The following is a description of a gene set: Genes predicted to be targets of miRBase v22 microRNA mmu_miR_1912_3p in miRDB v6.0 with MirTarget v4 prediction scores > 80 (high confidence targets). from publication Chen Y, Wang X (PMID 31504780) species: Mus musculus Mouse Gene Set: MIR_1912_3P, and this is the list of marker genes: Rnf13, Capza1, Csrnp1, Lrrc4c, Phf13, Chd7, Trim33, Slc8a1, Klhl14, A930018P22Rik, Unk, Clvs2, Robo2, Heg1, Cyld, Mndal, Wrnip1, Taok1, Cd200, Gabra6, Senp8, Lypla1 (NCBI Gene Id 18777), Aldh1a3, Rora (RAR-related orphan receptor alpha), Il1rapl2, Eif2s3x, Kmt2a, Grsf1, Nup205, Kcnk10, Rab7, Zmym2, Zcchc14, Gramd1c, Golm2, Fzd3, Tent5d, Slc39a13, Phf12, Rnmt, Vcl, Dazap2, Cav2, Gsr (glutathione reductase), Ube2n (NCBI Gene Id 93765), Zfp850, Cul4b, Zfp735, Kctd18, Stxbp5, Tmem163, Ide, Gls, Psap, Enpp2, Rgs16, Erbb2, Stab2, Pdpk1, Zfp704, Nap1l5, Eml5, Sec23a, Slc4a7, Acsl3, Ugcg (NCBI Gene Id 97164), Emc6, Cert1, Ttll7, Dapp1, Clcn3, Zfhx4, Tmbim1, Zdhhc24, Chd3, Zswim6, Asph, Rufy3, Ebf1, Ogfrl1, Pfkfb3, Pcbp1, Arnt2, Mea1, Atp7a, Serpina5, Itsn1, Ptprj, Serpine2, Rbbp5, Thumpd1, Fndc3b, Zfx, Zfp616, Ankrd13c, Krtap1-3, Lrrc7, Col19a1, Hsf2, Hipk3, Apbb2, Serpinb9f, Mapk6, Srsf7, Hoxb8, Rab40b, Hapstr1, Scai, Bdp1, Zeb2 (zinc finger E-box binding homeobox 2), Larp1, Ehmt1, Appl1, Magoh, Ppargc1a, Tgfb2, Tbx18, Sox5, Zfp608, Klf12, Lin54, Lrfn5, Dnajb4, Spred1, Sephs1, Sdc2, Ykt6, Tm7sf3, Trpc5, Lrba, Mapre1, Sytl5, Slc9a6, Rfx4, Gata3, Slc4a10, Tafa2, Synj1, Khdrbs3, Pnn, Sh3bgrl, Tmed8, Kcna1, Sult2a4, Slc16a6, Lrrn3, Kif13a, Dlx1, Ifi211, Ikzf2, Sgms1, Ttc3, Nup153, Ehd1, Lmod2, Bend4, Pdyn, Caprin1, Bmt2, Znrf3, Trem3, Asz1, Mapk10 (NCBI Gene Id 319641), Pptc7, Patj, Sorcs1, Eeig2, Recql, Ehbp1, Tdp2, Hoxd10, Mta1, Malt1, Nrip1, Nfat5, Ube2d1, Aak1, Arpc5, Hook3, Canx, Cep126, Cnot6, Atp2a2, Dpp10, Cxcl12, Efna5, Serpinb9g, Bmp7, Abca8b, Kcnj14, Cerk, Phf20, Ccdc126, Klhl31, Ube2g1, Bdnf, Ints8, Pbrm1, Zfhx3, Unc5d, Hdgfl3, Arhgef7, Stk31, Llph, Pcbp2, Prrg3 (NCBI Gene Id 208748, proline rich Gla (G-carboxyglutamic acid) 3 (transmembrane)), Luc7l3, Abr, Kdm1b, Zfp574, Cd53, Etl4, Ctdspl2, Mlycd, Tcaf3, Fnip1, Mtcl3 (NCBI Gene Id 67412), Atxn3, Sgpp1, Pou4f2, Zmat3, Dgkb, Nfia, Snx2, Semp2l1, Arfgef2, Spidr, Smpd3, Usp33, Plxnc1, Fndc3a (fibronectin type III domain containing 3A), Pip5k1a, Tvp23b, Tmem185a, Coa5, Celf4, Strbp, Surf6, Pikfyve, Dgat2, Otulin, Pja1, Tpd52, Kdm7a, Nup160, Mix23, Huwe1, Tent4a, Slc24a2, Matn2, Vcpip1, Ssb, Specc1, Fgd4, Srsf2, Irf2bpl, Dennd1b, Clasp2, Pyurf, Khdrbs1, Srgap2, Otud4, Bcor, Pcf11 (NCBI Gene Id 97363), Pak5, Ypel3, Gja8, Or51e1, Kbtbd6, Srsf1, Patz1, Pard6b, Kmt2c, Ppp6r3, Rsf1, Pde6a, Atf3, Fsd1l, Ppcdc (NCBI Gene Id 72037), Rb1cc1, Adgrg6, Camta1, Lpp, Zbtb14, Fbxl14, Zpbp, Daam2, Deup1, Hmgb3, Bnip3, Lsm11, Ralgapb, Arfgef1, Kmt2e, Pim2, Mideas, Mlh1, Igf2bp2, Lbh, Cadm2, Etv1, Rab18, Adamts2, Ubl3, Ppp3ca, Fip1l1 (factor interacting with PAPOLA and CPSF1), Nsmaf, Rapgef5, Klhl21, Slfn9, Tada1, Cdk1, Lzic, Hk2, Ifi205, Smurf1, Cast, Ppp5c